The following is a description of a gene set: The process leading to shortening and/or development of tension in the urinary bladder smooth muscle tissue involved in the expulsion urine from the body. Mouse Gene Set: GOBP_SMOOTH_MUSCLE_CONTRACTION_INVOLVED_IN_MICTURITION studied in species Mus musculus, and this is the list of marker genes: Tacr1, Trpv1, Kcnma1, Cacna1c (NCBI Gene Id 619317), Ptger3